Given this list of marker genes Ssb, Xkr6, Rdh12, Zbtb4, Treml2, Kpna1, Pla2g10, Rtp2, Cplx2, Map3k9, Cdc42ep3, Vkorc1, Grap2, Faf2, Polr3f, Fbxw11, Kndc1, Zfp85, Slc8a3, Dclk1, Loxl4, Sdk1, Stk11ip, Gas7, Itga9, Hmga2, Prrx1, Ccdc7a, Cd2ap, Ptger4, Thsd4, Elk3, Wnt3, Alg6, Cyp4f37, Vipr1, Nav1, Gzf1, Slc2a1, Ccdc6, Emp2, Ttc7b, Sestd1, Rasgef1a, Gnb1, Pdss2, Neurog2 (NCBI Gene Id 11924), Plch1, Ddb1, Fgf12, Aldh1l2, Trim33, G0s2, Bod1l, Add2, Tmem178b, Trim39, Myo9b (NCBI Gene Id 17925), Grb10, Gpr55, Egr3, 4833439L19Rik, Rab3b, Ehf (NCBI Gene Id 99194), Ppargc1b, Cdh20, Crispld2 (NCBI Gene Id 78892), Prkca, Zfp704 (NCBI Gene Id 269407), Insr, Angpt1, Ccny, Jaml, Msh3, Klf15, Usp11, Tab2, Rgs5, 4930453H23Rik, Col1a2, Golga1, Cdk5r1 (cyclin dependent kinase 5, regulatory subunit 1), Sstr3, Tmem263, Gcnt2, Gli3, Lrrc19, Plxna2, Zfp384, Ildr2, Sirpa, Rab3c, Dennd5a, Nqo2, here is a description of the gene set: Genes predicted to be targets of miRBase v22 microRNA mmu_miR_320_5p in miRDB v6.0 with MirTarget v4 prediction scores > 80 (high confidence targets). species: Mus musculus Mouse Gene Set: MIR_320_5P from publication Chen Y, Wang X (PMID 31504780)